Given this list of marker genes NRIP3, EBF4, ITPKB, MIR187, NEDD4 (NCBI Gene Id 4734), CD99L2, HDHD5, TMCC2, KCNIP2, GAB2, ACACB, GDF10, ANKRD9, LRRC9, SEMA6B, SPATA13, B4GALT5, PROZ, CACNG1, PRSS33, PHF19, MIR542, KRTAP4-7, HDAC5, PIP5K1A, PLEKHF1, WNT10B, SNX20, CDR2L, MS4A14, CD302, TTC7A, STX11, PINK1 (NCBI Gene Id 65018), DCTPP1, TNKS1BP1, NKAIN3, LPAR3, TECTB, RNF220, TSHZ3 (teashirt zinc finger homeobox 3), FCER1G, VEGFA, CDKN2B, IRAK1BP1, TRIB1, HDAC7, RCN1, HMX1, ABLIM2, PHYHD1, RNF144A, E2F2, HSPB7, AQP5, SEMA7A (NCBI Gene Id 8482), EIF4EBP1, CLK3, ST8SIA5, TMPRSS7, ERF (NCBI Gene Id 2077), CDC42EP5, CALCOCO1, HOXB2, AGFG2, MDGA2, PLEC (NCBI Gene Id 5339), MOS, ZFYVE28, ABLIM3, CHST5, RPUSD1, ADA, KCNK13, MRPL30, KCTD1 (potassium channel tetramerization domain containing 1), RNF208, PTMS, HERPUD1, SIGLEC5, ITPK1, PVR, PTK2B, HTR1A, CLEC3B, AQP6, TFEB, FAM3B, IL3RA, SAMD12, KIF12, BRI3BP, KCNN4, PPM1D, RASL11B, FSD1L, TWF2, TENT5B, GLP2R, NPR3, SPRR4, ATP6V1E1, UCK2, FRAT1, BARX2, ADCY1, DNAJC6, ADAMTS10, MBD2, DHRS2, TMEM158, HGF, PRM1, EVA1B, PGM1, SNX10, TMEM220, NPVF, KRTAP1-3, CCDC42, RIMS3, FUT7, THY1, SNCAIP, RTN4RL2, PLBD1, UBE2G2, FCGRT, INSYN2A, INPP4A, ZFPM1, MED13L, PHACTR2, EGFL6, HFM1, WDR38, MARCHF9, PNMA2, EFCAB8, MRPS11, ITGAD, NFYB, SETD1B, AAAS, NGFR, GPR33, PTPRD, SEMA4A, here is a description of the gene set: Genes down-regulated in wildtype DN3 thymocytes versus T cell lymphoma cells from TCF7 knockout. Human Gene Set: GSE33292_DN3_THYMOCYTE_VS_TCF1_KO_TCELL_LYMPHOMA_DN from publication Yu S, Zhou X, Steinke FC, Liu C, Chen SC, Zagorodna O, Jing X, Yokota Y, Meyerholz DK, Mullighan CG, Knudson CM, Zhao DM, Xue HH (PMID 23103132) TCF-1 is an HMG family transcription factor which is known to be critical for T cell development. We discovered that it has a unique role in suppressing malignant transformation of developing thymocytes at early stages. We identified ID2 and LEF-1 as key TCF-1 target genens in tumor suppression. We used microarrays to detect gene expression changes in WT and TCF-1 deficient DN3 thymocytes as well as T cell lymphoma cells developed in TCF-1 KO mice. studied in species Homo sapiens